Given this list of marker genes NECTIN3, RTN4, FBXL2, SYT10, E2F3, ID4, NT5DC1, SOCS5, OSMR, THRSP, FBN2, FEM1C, RALA, GGA2, EBF1, TTC14, TMEM64 (transmembrane protein 64), TUBGCP4, RBX1, DNAJC27, RHOQ, SERPINB1, BCAS2, OXGR1, TOB1, TMEM33, SEC24A, LINC01517, DUSP11, VAMP3, SGK3, AKIRIN2, ENKUR, FAM169A, SPIN1, VPS53, ECI2, ATRN, ADAM18, LRRC57, PSD3, ATRX, BMPR2, ANP32E, FAM177A1, ZNF326, ZNF143, ARFGEF3, SVIP, ELSPBP1, NBEA, CBFB, MIA2, CCT6A, BHLHE40 (NCBI Gene Id 8553), MSH3, ZSWIM5, DOCK3, ZNHIT3, TMEM167A, NAB1, PRR13, SLC9A9, PACSIN1, SAV1, MAGOHB, CEP68, ANO2, PHF20L1, STOM, here is a description of the gene set: Human Gene Set: MIR100_3P Genes predicted to be targets of miRBase v22 microRNA hsa-miR-100-3p in miRDB v6.0 with MirTarget v4 prediction scores > 80 (high confidence targets). species: Homo sapiens from publication Chen Y, Wang X (PMID 31504780)